The following is a description of a gene set: Thirty-eight PBMC samples from 25 patients with IPF and 13 matched controls yielded 149,564 cells that segregated into 23 subpopulations. Classical monocytes were increased in progressive and stable IPF compared to controls (32.1%, 25.2%, 17.9%, respectively, p<0.05). Total lymphocytes were decreased in IPF vs controls, and in progressive vs stable IPF (52.6% vs 62.6%, p=0.035). Tregs were increased in progressive vs stable IPF (1.8% vs 1.1% of all PBMC, p=0.007), although not different than controls, and may be associated with decreased survival (P=0.009 in Kaplan-Meier analysis; P=0.069 after adjusting for age, sex, and baseline FVC). Flow cytometry analysis confirmed this finding in an independent cohort of IPF patients. Fraction of Tregs out of all T cells was also increased in two cohorts of lung scRNA-seq. CCL22 and CCL18, ligands for CCR4 and CCR8 Treg chemotaxis receptors, were increased in IPF. The single-cell atlas of the peripheral immune system in IPF, reveals an outcome-predictive increase in classical monocytes and Tregs, as well as evidence for a lung-blood immune recruitment axis involving CCL7 (for classical monocytes) and CCL18/CCL22 (for Tregs). (From Abstract) studied in species Homo sapiens Genes downregulated in Dendritic cells from Idiopathic Pulmonary Fibrosis Patients vs. Controls Human Gene Set: UNTERMAN_IPF_VS_CTRL_DC_DN from publication Unterman A, Zhao AY, Neumark N, Schupp JC, Ahangari F, Cosme C Jr, Sharma P, Flint J, Stein Y, Ryu C, Ishikawa G, Sumida TS, Gomez JL, Herazo-Maya JD, Dela Cruz CS, Herzog EL, Kaminski N (PMID 38717443), and this is the list of marker genes: EGR1, DUSP2, BTG2, ZFP36, HLA-DRB1, SGK1, GPR183